The following is a description of a gene set: Hypoplastic helices species: Homo sapiens Underdevelopment of the helix, i.e., of the outer rim of the pinna. Human Gene Set: HP_HYPOPLASTIC_HELICES, and this is the list of marker genes: AGO2, PBX1, PLCB4, FRAS1, HOXA2, PAH (NCBI Gene Id 5053), AASS, GNAI3, FOXP1, TFAP2A